The following is a description of a gene set: Human Gene Set: GOBP_POSITIVE_REGULATION_OF_FEVER_GENERATION Any process that activates or increases the frequency, rate, or extent of fever generation. species: Homo sapiens, and this is the list of marker genes: TNF, PTGS2, IL1B, TNFSF11, TNFRSF11A, PTGER3